The following is a description of a gene set: To identify signature genes that help distinguish (1) sepsis from non-infectious causes of systemic inflammatory response syndrome, (2) between Gram-positive and Gram-negative sepsis. Genes up-regulated in peripheral blood monocytes (PMBC):healthy versus Gram positive sepsis. Human Gene Set: GSE9960_HEALTHY_VS_GRAM_POS_SEPSIS_PBMC_UP species: Homo sapiens from publication Payen D, Lukaszewicz AC (PMID 19535937), and this is the list of marker genes: GAB2, NAXE, OSTC, ACOT13, RNF149, EVA1B, KLHL7, RAB14, ANKFY1, CHRNA3, ZNF541, BRK1, EBP, LRFN3, PRXL2A, COQ2, ZNF677, LRIG1, C22orf39, KLF2, CISD3 (NCBI Gene Id 284106), SLC66A2, XPOT, A4GNT, COA5, SNRPC, SLC16A1, C14orf119, BRF1 (BRF1 RNA polymerase III transcription initiation factor subunit), RPS17P5, INIP, KIAA1586, FDXACB1, SOX13, RPL41, PPP1CA, MTO1, MAP7D1, GNB5, ATP6V0E2, SCAMP1 (secretory carrier membrane protein 1), ZNF548, HRK, RACK1, TMEM106B (NCBI Gene Id 54664), AGPAT2, SLIRP, HINT1, ROMO1, ARRDC2 (arrestin domain containing 2), CMTM3, ZFP69B, DRAM2, EOLA2, NOXA1, BTD, TSC22D3, RXRB, HTT, UBE2Q2, ABHD17A, CCDC28A, SNHG29, VAMP7, DCBLD1, DCAF12, SUN3, VARS1 (NCBI Gene Id 7407), PLEKHO2, SIGIRR, ZNF599, H2AZ2, ZNF232, PWWP2B, ZNHIT1, ATP5MJ, SIK1, EMC4, DPY30, CIB1, A1CF, ANAPC11, COX7A1, PDS5A, TRIM52, HSF1, TRPC1, C17orf100, RPS6, UBL5, EXOC6, ATP5IF1, PPIH, SSNA1, METAP1, EPN2, ACSS2, SLC35B2, MEGF6, PYHIN1, OST4, KDELR2, TNFRSF13B, CKLF, TMEM70, FAM185A, GMDS, TOMM22, FBXO31, SNAP29, SNU13, ARL3, CLEC11A, RTN3, ARHGAP30, BRD3, NDUFB6, MRPL58, RPS8, POLB, GUK1, CUL4B, TMEM256, MAPK14, GTF2A2, TXNDC17, GDE1, RPP25L (ribonuclease P/MRP subunit p25 like), OPRL1, CTDSP1, FMR1NB, KLKB1 (kallikrein B1), JPH4, DOCK1, PSENEN, LMBRD1, CELSR1, RNF220, ADNP, RSU1, CACYBP, SMIM15, RPS25, CCDC13-AS2, EPHB6, ATP5PF, SLC46A2, NHP2, SLC12A2-DT, VTI1B, CAMTA1, TMEM14B, PIGY, KCTD3, RDH12, FAM81A, NENF, POLR1D, NLRP12, RALBP1, RPL15, ECE2, ZMAT5, ACOXL, NKRF, PUDP, RBBP7, TMCC1, SETX, CETP, MAP3K9 (NCBI Gene Id 4293), ETF1, BAIAP2-DT, RPL26, EMC1, ADGRL2, KLHL3, CHCHD2, RPS16, IMPDH2, BLOC1S3, TRIAP1, SCRN2, C5orf24, PLPBP, EEF1D, COX7A2L (cytochrome c oxidase subunit 7A2 like), BST1, CISD2 (CDGSH iron sulfur domain 2), BPNT2, ACADS, GLCE, TXNRD3, TMEM107, GMPR2